The following is a description of a gene set: Human Gene Set: MIR3170 from publication Chen Y, Wang X (PMID 31504780) Genes predicted to be targets of miRBase v22 microRNA hsa-miR-3170 in miRDB v6.0 with MirTarget v4 prediction scores > 80 (high confidence targets). species: Homo sapiens, and this is the list of marker genes: PPM1H, EPHA3, ZNF345, RIMS2, SLC38A4, MEOX1, DPP8, FRS2 (NCBI Gene Id 10818), RORC, IGLL5, RASAL2, CCDC82, IMPG1, MEF2D, CC2D1A, SUMO3, POC1B, GUCA1B, DCP1B, FXN, ARHGAP12, CAMTA1, DLGAP4, SHTN1, SRPK1, CLIP3, SPACA9, CASP3, HELZ, TCAF1, PJA2, FBXL20, GRIK5, COL27A1, LTN1, NBN, SEC14L2, BRI3BP, HINFP, AHI1, C5orf22, ETV1, KPNA1, RABL3, CFAP210, ZNF470, BCAM, PCSK6, GUCD1, PPP1R9B